Given this list of marker genes BMP2, ITIH6, CAPN14, ERBB4, SEMA6D, SMC1B, ETFRF1 (NCBI Gene Id 144363), FER, CACNA1C, SLAMF7, CDK13, BDNF, GABRB2, TCAIM, ITGB1BP1, FGF13, NT5DC1, RFLNB, IGF1, KIF26B, CSF2RA, TRIO, IGSF21, RIC3, ZBTB20, MAGI1, SEC14L4, NLGN1, FOSB, M6PR, BCL11A, TGFB2, SLC3A2, ETFBKMT, WNT5A, ATP2B4, WAC, VCF2, KIAA1958, VWC2L, CLIP3, ALG14, EXO1, RALGPS1, FGGY, ERC2, CYP1A2, VNN1, SLITRK5, GTPBP8, TRHDE, NCAM2, PRR11, FAM168B, RNF217, DGKK, SMIM15, SPOP, BVES, KLF5, POU2F2, HTR1F, IMPA1, LINC02801, PDP2, CTSV (NCBI Gene Id 1515), MBLAC2, ROPN1B, RAB6A, ZSCAN25 (zinc finger and SCAN domain containing 25), MTF1, NAV3, NT5C2, RAVER2, NAT9, SLC46A3, LRRC4C, PCSK9, KLLN, COL10A1, ANGEL2, ITGA2, PKD2, PNISR, UBE2R2, TNRC6B, SLX4, ZIC5, OR2H1, LDOC1, TTC23L, PIP4K2A, TRNT1, LRRC58, CDIN1, SLC1A2, MARCHF1, CNTN1, RORA, IFI44L, TMEM212, ITIH5, SORD, TMOD3, MCC, ARFGEF3, MYL1, SETD7, PPP2R5E, CRACD, HDAC4, VPS13A, EPHA7, NIPAL2, YPEL1, ICOS, ZNF385D, ZNF280D, MSR1, MTG2, PTGR3, NEUROD2, VTCN1, SARAF, ATP6V0A2, PSMD11, NDP, ZEB2, INTS6, ZNF805, CDH24, LDLRAD3, TBRG1, TRAT1, ZFP3, TTC3, PLXDC2, FKBP2, SMAD9, KCNA1 (NCBI Gene Id 729214), RBFOX2, PRR27, ITPK1, PRRX1, CLDN1, ROR1, PDK1, ABCD2, CAVIN2, CDS1, ITGA4, PLCXD3, NACC2 (NCBI Gene Id 138151), HTR1B, PDZD2, ELK4, EBF1, NEGR1, UBE2L3, GNAI3, DNMT3A, XKR6, MYH11, THEM4, ST6GALNAC3, NAGK, QPCT, STYX, MKRN2, NALF1, THBS2, GABRB1, TNPO1, SLC44A4, CORO2A, PSG1, TP53AIP1, CD38, PECR, SYF2, RDH11, RBFOX1, TBX1, NEURL1B, LRRTM4, AASS, UNC5C, ZNF207, PATZ1, MYLK3, ZBTB18, EYA1, FOXI1, BOC, KAT6B, USP14, APOOL, SLC22A5, SPMIP1, ACSM3, GRAMD2A, BEX4, NR2F1 (nuclear receptor subfamily 2 group F member 1), NLK, CHMP5, ZFR2, RAF1 (NCBI Gene Id 5894), CYP27C1, TLCD5, PCDH18, SETD3, CMPK2, BCL2L15, NICN1, DAD1, FOXG1, ZNF782, GABRA4, PPM1A, PTGS1, REG4, KLHL28, KIAA0408 (NCBI Gene Id 9729), RBM47, HES2, RFWD3, ZFHX3, BCL11B, MMD, IFT56, PDE4D, SGIP1, ISL1, C1orf21, MPZL2, PALM2AKAP2, PHF14, LIN28B, UCK1, FBN1, FAM181B, SATB1, ZNF750, RAB3B, PDE12, BCKDHB, ZRANB3, PHF20L1, ALCAM, BSN, UNC79, RASA4, MAP4K3, IL15, CHTOP, PRDM1, PLPP3, PROKR2, TMEM123, ANKLE1, SYNPO2L (synaptopodin 2 like), ATP6V1A, HNRNPA2B1, CAPS2, MRPL57, DNAI7, CABCOCO1, TMEM86A, MIER3, VSTM4, MSL1, EYA4, PPP1R1C, LRRC3B, RBPJ, FAXC, RFK, LAMP2, TTC39A, RTKN2 (NCBI Gene Id 254060), CFAP251, HLTF, ALOX12B, B3GNT9, SSPN, SERPINB10, SLC39A8, HDDC2, ACVR2B, TMEM168, IQUB, GTF3C3, PIK3C2A, RNF125, BLOC1S6, PTPN12, EYS, LCOR, PAPOLA, DDX60L, RAB5B, ATXN10, LONRF1, LRRN3, SLFN5, VGLL3, BHMT, TBC1D8B, IFFO2, IGF2BP3, CDH2, LAMA2, RTN1, MAP6, TET3 (tet methylcytosine dioxygenase 3), IGSF10, FNDC9, DMD, CCDC190, RAB3GAP2, KPNA5, ARIH1, SLC39A10, ZNF334, EXTL2, ESRRG, POU3F3, AOPEP, ATAD5, NR2E1, GRIP1, MAP3K13, LDLRAD4, MAP3K15, NCOR1, ZBTB7A, SLC35A1, TMEM9B, IKZF3, LETM2 (NCBI Gene Id 137994), CSAD, CPM, TNFSF10 (NCBI Gene Id 8743), HIBADH, NR4A2, ADCY7, LSM5, SLC9A6, CNGB1, UBE2N, SLC31A2, SYT4, SCAI, PAX3, HNF1B (HNF1 homeobox B), PGS1, SH3BP4, PUM1, SLC18A2, FZD3, MRFAP1, FANCC, TMEM131, LINC03042, PTPN4, ABITRAM, DKK2, CASD1, TTC4, AJAP1, ZNF620, LSM12, H2AZ1 (H2A.Z variant histone 1), MDGA2, KLF8, SLCO1B1, FSD2, PAK3, NIPA2, APOLD1, WBP1L, POU2F1, FUT9, RIOX2, MAPDA, GRIA2, NUFIP2, MINDY2, CCSER2, TM9SF3, MECP2, SLC38A4, LGI2, MYCN, ZNF507, TENM2, TNS3, NBEAL1, SORCS1, WDR75, PURB, here is a description of the gene set: Human Gene Set: MIR8068 species: Homo sapiens from publication Chen Y, Wang X (PMID 31504780) Genes predicted to be targets of miRBase v22 microRNA hsa-miR-8068 in miRDB v6.0 with MirTarget v4 prediction scores > 80 (high confidence targets).